The following is a description of a gene set: Reactome Pathway: DNA strand elongation Accurate and efficient genome duplication requires coordinated processes to replicate two template strands at eucaryotic replication forks. Knowledge of the fundamental reactions involved in replication fork progression is derived largely from biochemical studies of the replication of simian virus and from yeast genetic studies. Since duplex DNA forms an anti-parallel structure, and DNA polymerases are unidirectional, one of the new strands is synthesized continuously in the direction of fork movement. This strand is designated as the leading strand. The other strand grows in the direction away from fork movement, and is called the lagging strand. Several specific interactions among the various proteins involved in DNA replication underlie the mechanism of DNA synthesis, on both the leading and lagging strands, at a DNA replication fork. These interactions allow the replication enzymes to cooperate in the replication process. part of: Synthesis of DNA species: Homo sapiens, and this is the list of marker genes: GINS2, PCNA, POLA2, LIG1, PRIM2, RPA3, PRIM1, MCM5, MCM2, MCM8, POLD1, RFC2, POLD3, RPA2 (replication protein A2), RFC4, POLA1, MCM4, RPA1, DNA2, FEN1, CDC45, GINS3, MCM3, MCM7 (minichromosome maintenance complex component 7), GINS1, POLD4, RFC3, MCM6, GINS4, RFC5, RFC1 (NCBI Gene Id 5981), POLD2